Given this list of marker genes Gzmb, Ly6e, Tnip1, Creb1, Tnfrsf18, Cyba, Krt83, Serpinb6b, Relb, Sdhaf1, Eif5a, Zfp36l2, Bcl2a1b, Cysltr2, Limd2, H2-K1, Marcksl1, Gbp4, Psme1, Gbp5, Tyk2, Calr, Jak2, Mapkapk2, Lta, Bcl2a1d, Psme2, Ccnd3, Ddit4, Med11, Igfbp4, Serpina3g, Zfp36l1, Birc3, Trp53, Abcc1, Nfkb2, Icam1, Bcl3, Pou2f2, Stat1, Pik3ip1, Batf, Ncf4, Odc1, Kdm2b, G3bp1 (NCBI Gene Id 97760), Ly6a, Parp14, Ikbke, Tap1, Ptp4a2, Ltb, Cd82, Il27ra, Rtp4, Stat6, Tapbp, Nfkbia, Gimap5, Stx11, Psmb9, Gramd2b, Apobec3, Cblb, B2m, Nfkb1, Serinc3, Pdcd1lg2 (NCBI Gene Id 58205), Psmb10, Adam8 (NCBI Gene Id 11501), here is a description of the gene set: Cytokines mediate cell-cell communication in the immune system and represent important therapeutic targets. A myriad of studies have highlighted their central role in immune function, yet we lack a global view of the cellular responses of each immune cell type to each cytokine. To address this gap, the authors created the Immune Dictionary, a compendium of single-cell transcriptomic profiles of more than 17 immune cell types in response to each of 86 cytokines (>1,400 cytokine-cell type combinations) in mouse lymph nodes in vivo. A cytokine-centric view of the dictionary revealed that most cytokines induce highly cell-type-specific responses. For example, the inflammatory cytokine interleukin-1β induces distinct gene programmes in almost every cell type. A cell-type-centric view of the dictionary identified more than 66 cytokine-driven cellular polarization states across immune cell types, including previously uncharacterized states such as an interleukin-18-induced polyfunctional natural killer cell state. Mouse Gene Set: CUI_T_CELL_GD_TNFA_RESPONSE_UP Genes positively differentially expressed in cell type: γδ T cell upon treatment with cytokine: TNF-α in mouse lymph nodes in vivo. species: Mus musculus from publication Cui A, Huang T, Li S, Ma A, Pérez JL, Sander C, Keskin DB, Wu CJ, Fraenkel E, Hacohen N (PMID 38057668)